The following is a description of a gene set: from publication Jeffrey KL, Brummer T, Rolph MS, Liu SM, Callejas NA, Grumont RJ, Gillieron C, Mackay F, Grey S, Camps M, Rommel C, Gerondakis SD, Mackay CR (PMID 16474395) Genes up-regulated in comparison of mast cells versus B cells. Human Gene Set: GSE3982_MAST_CELL_VS_BCELL_UP In the present study we used Affymetrix oligonucleotide microarrays to produce gene transcription profiles for the major leukocyte types in humans. This comprehensive dataset enabled us to not only establish which genes were expressed in each leukocyte type, but also which genes were expressed in each subset after activation. The used of a comprehensive dataset of gene profiles from all the major human leukocyte subsets enabled a novel and powerful means for identification of genes associated with single leukocyte subsets, or different immune paradigms. species: Homo sapiens, and this is the list of marker genes: SST, ALDH1A1, CLEC4M, CACNA1F, STX1A (NCBI Gene Id 6804), SOX4, TTC38, ZNF155, TSC22D1, CAMSAP2, PROCR, ELOVL4 (NCBI Gene Id 94678), SMYD3, S100A8, TBXAS1, PSMD1, LAPTM4A, GPD1L, BMP1, FAM200C, EEF1AKMT3 (EEF1A lysine methyltransferase 3), SLC25A15 (NCBI Gene Id 3089), PSMC2, BMERB1, FBP1, BST1 (NCBI Gene Id 683), RAD23B, ERO1A, SLC27A2, OTULINL, CNIH3, SLCO1C1, ITK, ABCC4, QPRT, SLC30A4, PKP4, FOSL1, ARRB1, SLAMF8, SMIM7, APMAP, NDUFB6, HAUS6, CCN3, CTTN, EFHC2, DEPTOR, ADRA2C, TALDO1, FAM171A1, OSBPL3, ATP12A, HP, CACNA2D2, CEACAM8, MANSC1, ATP5IF1, FLOT1, SV2A, SEM1, DYNLT1, CHMP3, DCTN6, TAOK3, MT1H, BACE2, NUPR1, MED21, WIZ, ST3GAL6, DHCR24, CALU, PRDX6, CD300A, MAB21L1, IDH1, PHACTR2, P2RX1, FYN, CCDC68, OLA1, DAPK1, REPS1, EXTL2 (exostosin like glycosyltransferase 2), PCOLCE, CYFIP1, PPP1R3A, DENND1B, ZNF175, CST7, TNPO3, ATP8A2, ELOVL6, CLTC, KPNA2, IPO7, RNF146, LANCL2, PPP1R3D, LMNB1, GSN, LIPA, SIN3B, CTSO, CLDN6, ACOT9, ABHD6, MTFR1, CD44, CRLF2, IL18RAP, LMNA, GPR31, SIGLEC6, SOCS2, SEMA4C, ST7 (suppression of tumorigenicity 7), ZSCAN31, H3-3B, A4GNT, KRTAP1-1, FRMD4B, PIK3R1, SEC14L4, GTF2H5, TREM2, CRISP3, RGS10, FCER1G, RSAD2, TP53BP2, PCTP, GLUL, SORBS1, NR0B1, F13A1, ATP10A (NCBI Gene Id 57194), GADD45A, BHLHE40, TBX3, ADGRA3, SOX13 (NCBI Gene Id 9580), LEPR, MS4A4A, LRP12, SCCPDH, EIF5A2, DUSP10, WT1, HNMT, CORO2A, SPP1, LAPTM4B, ALAS1, CCL2, GABARAPL1, ADI1, RMND5A, NEUROG2, BPI, CAVIN2, HES2, IPCEF1, SPRY2, SPA17, HRH1, CCL23, KRT6A, ANXA9, STX11, FOXO3, RCAN1, FRMPD1, FSCN1, COL14A1, ADGRE3, LYSET, YES1, HOXB6, SERINC3, P4HA2, GRB10, PAPSS1, PCDHB11, ENY2, ATP5F1C, ITPRID2, PPM1H, TM6SF2, RECQL4, DRAM1, SMARCD3, RHOBTB1, MFGE8, HK2, AKAP12, FCGR3B, IL1R1, ZFR2